The following is a description of a gene set: Human Gene Set: NADLER_OBESITY_UP Genes up-regulated in adipose tissue from obese mouse strains compared to the lean ones. species: Mus musculus Obesity is strongly correlated with type 2 diabetes mellitus, a common disorder of glucose and lipid metabolism. Although adipocytes are critical in obesity, their role in diabetes has only recently been appreciated. We conducted studies by using DNA microarrays to identify differences in gene expression in adipose tissue from lean, obese, and obese-diabetic mice. The expression level of over 11,000 transcripts was analyzed, and 214 transcripts showed significant differences between lean and obese mice. Surprisingly, the expression of genes normally associated with adipocyte differentiation were down-regulated in obesity. Not all obese individuals will become diabetic; many remain normoglycemic despite profound obesity. Understanding the transition to obesity with concomitant diabetes will provide important clues to the pathogenesis of type 2 diabetes. Therefore, we examined the levels of gene expression in adipose tissue from five groups of obese mice with varying degrees of hyperglycemia, and we identified genes whose expression strongly correlated with diabetes severity. This group included many genes that are known to be involved in signal transduction and energy metabolism as well as genes not previously examined in the context of diabetes. Our data show that a decrease in expression of genes normally involved in adipogenesis is associated with obesity, and we further identify genes important for subsequent development of type 2 diabetes mellitus. from publication Nadler ST, Stoehr JP, Schueler KL, Tanimoto G, Yandell BS, Attie AD (PMID 11027337), and this is the list of marker genes: COL1A1, FXYD5, NEDD8, GRN, SEC13 (SEC13 homolog, nuclear pore and COPII coat complex component), UCP2, CTSD, TPD52, CTSK, LEP, LAPTM5, C1QB, FCER1G, CTSB, CRYAB, DYNLT1, MIF, FBLN2, POSTN, PEA15, IFI27 (NCBI Gene Id 3429), LBP, CFL1, FLNA, LGMN, TLN1 (NCBI Gene Id 7094), CD53, CCL15, ATP6V1C1, ALOX5AP, CTSS, SELPLG, PLIN2, LGALS3, PLD3, TPM4, MRC1, DAD1, PITPNA, CKB, HCLS1, PLTP, CAPG, FCGR2A, CSTB, CTSV, BGN (biglycan), PFN1, CSF1R, PSAP, CTSA, LRP1, MT1X, BASP1, IFI30, CD68, CTSZ, SERPINF1, DUSP1, MFGE8